The following is a description of a gene set: Mouse Gene Set: chr3G1 species: Mus musculus, and this is the list of marker genes: Extl2, Gm9379, Rtca, Gm10652, Gm9369, 4930447N08Rik, Gm9889, Gm9381, Gm17494, Fnbp1l, Ndst4, Gm29736, Sec24d, Gm9372, Gm26544, Gm19243, Slc30a7, 4921521D15Rik, Gm18430, Myoz2, Gm15551, Slc35a3, Gm9761, Gm18916, Synpo2, Gm5981, Gm22337, Lrrc39, 4633401B06Rik, Gpr88, Gm23733, Gm9361, Mir7657, Trmt13, Ndst3, Gm23432, Gm9632 (NCBI Gene Id 674908), Frrs1, Gm32444, 4921527H02Rik, Gm5710, Dph5, Gm40190, Gm9353 (predicted gene 9353), 1700003H04Rik, Palmd, Usp53, Mir760, Rwdd3, Arhgap29, Gm18384, 4930455H04Rik, S1pr1, Mfsd14a, 4930512P04Rik, Gm6649, 1810037I17Rik, Gm30517, Vcam1, Gm20568, Slc44a3, F3, Gm35065, A530020G20Rik, Mir669n, Snx7, Prss12, Gm4332, Plppr5, Gm22575 (NCBI Gene Id 115489774), A930005H10Rik, Gm23440, Abca4, Plppr4, Mettl14, Gm5711, A730020M07Rik, 1700061I17Rik, Gm4609, Gm15400, Tram1l1, Abcd3, Gm22361, Gm9364, Snora24, Gm6061, Fabp2, 1700006A11Rik, 5330425B07Rik, Sass6, Alg14, Gm43568, Dbt, Gm9916, Ugt8a (NCBI Gene Id 99902), 4930432M17Rik, Cnn3, Gm31651, Cdc14a, Agl, Gm9332, Gm18429, Gm24458, Gm25013, Ptbp2, Gm26358, Gm34139, Camk2d, Mir137, Gclm, Bcar3, Gm4617, Dnttip2, 6530403H02Rik, Pde5a, 4933405D12Rik, Arsj (NCBI Gene Id 271970), Snhg8, Tlcd4, Dpyd, Gm22713, Gm4610 (NCBI Gene Id 100047914), Gm4321, Gm4596, Gm26871